Given this list of marker genes TOB1, PRDM1 (PR/SET domain 1), RUNX3, CD3G, HLA-F, SPN, CARINH, FCRL6, MYL12A, CALM1, OPTN, BCL11B (BCL11 transcription factor B), TPST2, STAT4, RPL27A, SIGIRR, SSBP4 (single stranded DNA binding protein 4), BTN3A1, MYO1G, RPS3, CDC25B, CD8B, SLA2, TBX21, MATK, SAMD3, SPON2, APOBEC3G, FGFBP2, CAPN2, TBC1D10C, SYTL3, PLAAT4, SUN2, B2M, S1PR5 (NCBI Gene Id 53637), SH2D1A, SLFN5, SYNE2, CST7, PTP4A2, LSP1, RPS4Y1, PIP4K2A, TGFBR3, RPS27, CD2, ZFP36L2, GZMB, LAG3, MBP, KLRG1, CHST12, SYNE1, LCK, PRKCH, CX3CR1, RORA, SH2D2A, TRG-AS1, ARPC5L, IL10RA, NKG7, IL32, TLE5, SEPTIN1, ZBTB38, LYAR, PFN1, ARL4C, MALAT1, GNG2, F2R, KLRF1, RAB27A, EOMES, CDC42SE2, HLA-A, RNF125, CNOT6L, CMC1, RPL23A, ETS1, ANXA6, NHERF1, EMB, AKNA (AT-hook transcription factor), CRTAM, GNLY, CCND2, ITK, PLEKHF1, IFITM1, PRF1, HLA-B, CD7, CCND3, KLRD1, PPP2R5C, AAK1, PRSS23, BTN3A2, CCL5, TC2N, HCST, CD96, PTPN4, ITGAL, GZMH, GZMM, SLAMF6, MIAT, SYNGR1, RASAL3, GZMA, GFI1, TIGIT, C12orf75, CD8A, ADGRG1, SPOCK2 (NCBI Gene Id 9806), CTSW, ITGB2, PYHIN1, ABHD17A, APMAP, TUBA4A, TTC38, PRKACB, FYN, RAP1B, KLF2, S1PR4, SKAP1, C1orf21, ZAP70, TSEN54, PTGDR, BIN1, CD3E, IKZF3, IL12RB1, ISG20, CD3D, here is a description of the gene set: studied in species Homo sapiens from publication Travaglini KJ, Nabhan AN, Penland L, Sinha R, Gillich A, Sit RV, Chang S, Conley SD, Mori Y, Seita J, Berry GJ, Shrager JB, Metzger RJ, Kuo CS, Neff N, Weissman IL, Quake SR, Krasnow MA (PMID 33208946) Human Gene Set: TRAVAGLINI_LUNG_CD8_NAIVE_T_CELL